Given this list of marker genes CGA, UTS2, GH1, CHGB, PPY, MLN, QRFP, INHBA, NMB, SCT, CORT, GNRH2, INSL5, C7orf50, CGB1, LEP, CALCB, INHBB, INHBC, INHA, GPHA2, INSL3, GCG, ADM2, PMCHL2, CGB7, PYY, THPO, VIP, PRL, OSTN, GUCA2A, ADM, PTH, NPFF, APELA, RETN, FSHB, APLN, PTHLH, EDN2, CALCA, REG3A, AVP, UCN3, TOR2A, GRP, AGT, GALP, TTR, INSL4, C1QTNF9, IAPP, HCRT (NCBI Gene Id 3060), INS-IGF2, ENHO, UCN, EDN3, SST, UCN2, COPA, TRH, PRLH, POMC, NPPC, KL, AGRP, INSL6, ADCYAP1, GHRL, EPO, OXT, INHBE, GH2, IGF2 (NCBI Gene Id 492304), PNOC, KNG1, GFRAL, METRN, CGB3, PENK, ANGPTL8, C1QTNF12, FBN1, NPPA, AMH, PMCH, ECRG4, VGF, ERFE, CCK, NPY, IGF1, RLN2, RLN3, STC2, RLN1, CSH2, GAL, UTS2B, BMP10, CRH, HAMP, GPHB5, ADIPOQ, FNDC5, EDN1, PYY3, NTS, GDF15, METRNL, TG, CGB2, TSHB, ASIP, SPX, GHRH, FBN2, CCL25, LHB, GIP, CSHL1 (chorionic somatomammotropin hormone like 1), BGLAP, INS, GNRH1 (gonadotropin releasing hormone 1), CCN3, RETNLB, GAST, NPPB, CSH1, STC1, CARTPT, here is a description of the gene set: Human Gene Set: GOMF_HORMONE_ACTIVITY The action characteristic of a hormone, any substance formed in very small amounts in one specialized organ or group of cells and carried (sometimes in the bloodstream) to another organ or group of cells in the same organism, upon which it has a specific regulatory action. The term was originally applied to agents with a stimulatory physiological action in vertebrate animals (as opposed to a chalone, which has a depressant action). Usage is now extended to regulatory compounds in lower animals and plants, and to synthetic substances having comparable effects; all bind receptors and trigger some biological process. studied in species Homo sapiens